Given this list of marker genes PRKACA, SELENOM, MIER3, CHRNA3, GRIN2B, DCTN3, PRUNE1, SYPL1, JAM3, RAMAC, KIF20A, C19orf12, CCNDBP1, MACO1, TSPAN3, GDE1, ACAP3, CHST8, CDC123, C1orf198, SNX17, CDCA7L, PRRC1, FAF1, CYP11B2, GCDH, TCAF1, AIP, HAGHL, TMEM205, RNF112, ELMO3, MARVELD3, SDF2L1, EFNB2, HMG20A, SLC32A1, ADPRH, VRK2, DGKZ, NXPH4, ADAP2, PDCD6, PRKAG2, DICER1 (NCBI Gene Id 4333), COPS5, RHBDD3, KRCC1, MEIS2, SSPN, SLC6A5, SPSB3, CAMKK1, SLC1A2, GPLD1, WBP4, MKNK2, ULK2, USP17L2, FRA10AC1, TMUB2, CCSAP, FCN1, TMEM72, FCSK, NDUFS1 (NADH:ubiquinone oxidoreductase core subunit S1), ASPHD2 (aspartate beta-hydroxylase domain containing 2), CDC6, SLC12A8, USP15, GRHL2, MGAT2, INHA, CDKL1, ARSI, PEAR1, ZNF385C, SLC25A38, KRT82, SNAPC5, CMTM7, SERPINA12, OPRM1, DLG3, MTSS1, PNPLA3, UBE3D, MED30, TEDC1, FLRT1, DCTN2, COA4 (cytochrome c oxidase assembly factor 4 homolog), ACTL6B, H2AC25, EGFLAM, SH3BP5L, WEE2 (WEE2 oocyte meiosis inhibiting kinase), RELL1, MUL1, SHLD1, CTXN1, HIGD1C, CHRNA6, CLCA4, CRYL1, NDRG3, INSC, FMO4 (NCBI Gene Id 2329), INTS10, ASRGL1, CCDC28A, MATCAP1, STYXL2, ACSBG2, CCDC92, YIPF7, ADCY9, AIFM1, UPK2, AKIP1, PLB1, CCDC102A (NCBI Gene Id 92922), FOCAD, FFAR4, CHD6 (chromodomain helicase DNA binding protein 6), CYP19A1, BRIP1, GDF11, ANKRD54, MOK, MON1A, MEDAG, TMEM121B, SCNN1A, PDLIM2, FGF5, RAD51AP1, NIPAL3, RNF167, SLC4A11, KRTAP20-2, SDR42E1, AURKAIP1, HMGXB4, HYPK, GLE1, DIO1, KRT7, HTATIP2, PIP4K2A, IRX3, FAIM2, PRRX2, MAP4K3, ARFIP2, DCAF15, CD200R1L, LSM14B, C12orf50, UBE2G1, MORN2, HPS4, FEZ1, GPR20, PLEKHH2, SPPL2B, TLE6, LPO, COQ10A, PFN4, PTGES3, TNP1, CEL, GALNT9, NCOA2, CTRL, ACBD7, RBMS2, SMPD1, BCKDK, KCNF1, KIF22, HLA-DOA, CD3E, TCEAL9, SMCO1, ITGB1BP1, NCBP2AS2, TMEM17, BICRAL, CTBS, CYB561D2, ZBTB11, PGRMC2, OSR1, CMKLR1, ABHD8, VPS16, SDHA, here is a description of the gene set: Human Gene Set: GSE21546_WT_VS_ELK1_KO_DP_THYMOCYTES_DN Genes down-regulated in untreated double positive thymocytes: wildtype versus ELK1 knockout. from publication Costello P, Nicolas R, Willoughby J, Wasylyk B, Nordheim A, Treisman R (PMID 20554967) Removal of the transcription factor SAP1a member of the Ternary Complex Factor (TCF) group of transcription factors which in conjunction with Serum Response Factor (SRF) has been shown to have a profound effect on positive selection in the thymus. When another TCF Elk1 is knocked out in mice there is no effect on positive selection unless it is on a Sap1a KO background where the phenotype is very severe. We have stimulated isolated double positive T cells (DPs) with anti-CD3 to mimic positive selection and compared basal and stimulated transcription across the four genotypes to discover the downstream targets of Sap1a involved in positive selection. species: Homo sapiens